Given this list of marker genes Fgfbp3, Fgf10, Fgf3, Fgfbp1, Fgf1, Fgf7 (NCBI Gene Id 14178), Fgf2, Fgf22, here is a description of the gene set: FGFR2b ligand binding and activation species: Mus musculus Mouse Gene Set: REACTOME_FGFR2B_LIGAND_BINDING_AND_ACTIVATION